The following is a description of a gene set: This event has been computationally inferred from an event that has been demonstrated in another species.<p>The inference is based on the homology mapping from PANTHER. Briefly, reactions for which all involved PhysicalEntities (in input, output and catalyst) have a mapped orthologue/paralogue (for complexes at least 75% of components must have a mapping) are inferred to the other species. Reactome Pathway: Arachidonate metabolism studied in species Mus musculus electronically inferred by orthology from the curated human pathway part of: Fatty acid metabolism, and this is the list of marker genes: Aloxe3, Cyp1a2, Alox12b, Tbxas1, Ptges2, Cyp1a1, Akr1c21, Cyp2c66, Cyp2u1, Cyp4f18, Ggt5, Lta4h, Cyp4f15, Cyp4a29 (NCBI Gene Id 230639), Gpx1, Ephx2, Akr1c6, Alox12, Cyp4a12a, Cyp2c65, Cyp8b1, Cyp1b1, Pon1, Awat1, Akr1c14, Cyp4a10, Alox15, Ltc4s, Ggt1, Gpx4, Ptgds, Alox8, Cyp2j6, Ptgs2, Dpep2, Cyp4b1, Cyp4a31, Akr1c20, Ptgis (NCBI Gene Id 19223), Gpx2, Hpgds, Pon3, Ptgs1, Cyp4a30b, Dpep1, Akr1c13, Alox5ap, Cyp4f39, Faah, Akr1c18, Cyp4f40